The following is a description of a gene set: Human Gene Set: WP_MIRNA_REGULATION_OF_PROSTATE_CANCER_SIGNALING species: Homo sapiens miRNA regulation of prostate cancer signaling, and this is the list of marker genes: MAP2K1, PDGFRB, MTOR, MIR1299, MIR603, SOS1, BAD, NFKBIA, PDGFA (NCBI Gene Id 5154), TCF7, MAPK1, MIR3149, CTNNB1 (NCBI Gene Id 1499), MIR589, MIR3682, MIR4325, MDM2, CASP9, MIR337, MIR4763, KLK3, CDKN1A, MIR4517, MIR30D, GRB2, RAF1, AKT3, CDKN1B, MIR4664, MAP2K2, MIR4311, BCL2, NFKB1, CREBBP, TP53, GSK3B (NCBI Gene Id 2932), MIR363, CCND1, CREB3L1, MIR3714, MIR200A, MIR3664, MIR3120, IKBKG, MIR466, KRAS, PIK3CA, FOXO1, AR